The following is a description of a gene set: Catalysis of the reaction: 1-phosphatidyl-1D-myo-inositol 3,5-bisphosphate + H2O = 1-phosphatidyl-1D-myo-inositol phosphate + phosphate. species: Mus musculus Mouse Gene Set: GOMF_PHOSPHATIDYLINOSITOL_3_5_BISPHOSPHATE_PHOSPHATASE_ACTIVITY, and this is the list of marker genes: Ptprq, Mtmr2, Mtmr14, Sacm1l, Mtmr6, Mtmr4, Fig4, Inpp5e, Mtmr7, Mtmr1 (myotubularin related protein 1), Mtm1, Mtmr3